The following is a description of a gene set: Human Gene Set: GSE23308_CTRL_VS_CORTICOSTERONE_TREATED_MACROPHAGE_MINERALCORTICOID_REC_KO_DN from publication Usher MG, Duan SZ, Ivaschenko CY, Frieler RA, Berger S, Schütz G, Lumeng CN, Mortensen RM (PMID 20697155) studied in species Homo sapiens Inappropriate excess of the steroid hormone aldosterone, which is a mineralocorticoid receptor (MR) agonist, is associated with increased inflammation and risk of cardiovascular disease. MR antagonists are cardioprotective and antiinflammatory in vivo, and evidence suggests that they mediate these effects in part by aldosterone- independent mechanisms. We used affymetrix to characterize the effect of Mineralocorticoid Receptor deletion on macrophage transcriptional profile, and identify its requirement in normal glucocorticoid signalling. Genes down-regulated in macrophages with NR3C2 knockout: untreated versus corticosterone., and this is the list of marker genes: NFIA, AP1S2, PSMB7, NFXL1, DCTPP1, RCSD1, SERPINE1, E2F8, RUFY3, B4GALT1, IRF1, ENDOD1, RIPK2, VCAM1, GEM, VOPP1, MOB1B, MOCOS, TSTD2, SEC23A, GLB1, SAT1, IL1A, SLAIN2, HINT3, RNF115, XIAP, DEK, CWC15, TOX4, ACADSB, B4GALT6, TCF4, TP53INP2, SNRPB2, TMED5, TUBB2A, SIAH2, SLC16A7, GLOD4, FNBP4, HERC1, CLIP1, ST13, RAB29, TEP1, CCNJ (cyclin J), IL10RA, WDR46, CHUK, PPT1, NFKB1, CAAP1 (NCBI Gene Id 79886), ZC3H7A, GSS, PDCD4 (NCBI Gene Id 27250), ARRDC4, RNASE4, SPAG7, AGPAT3, STK4, HMGB2, PHKB, MTMR14, TNS1, SGCB, SNRPC, KLHL25, CASP3, CMPK2, MALAT1, TRAPPC2B, PRC1, DYNC1H1, ARHGEF3, EDEM1, ARHGAP21, APTX, DPY30, CNOT7, WDR36, ARRB1, RYR1, CCPG1, MPC1 (NCBI Gene Id 51660), DHPS, ARHGAP4, B3GALNT1, SH3BP5, SEMA4D, PFKP, ABCB7, NFKBIE (NCBI Gene Id 4794), ANKRD44, ABCC1 (ATP binding cassette subfamily C member 1 (ABCC1 blood group)), THRA, APAF1, IDH1, ATP5F1C, TRIM21, LIG1, DOCK7, RBM7, RTRAF, PCNX1, DLAT, TMLHE, GTF2B, METTL5, IDH3G, STX6, ITSN2, SLC29A1, PARVG, HBS1L, MTCP1, COX15, SOCS1, PHTF2, TBK1, NOA1, PDLIM5, TRAM1, CSF1 (colony stimulating factor 1), CYB5A, TMEM184B, ENPP4, HMGB3, LIN9, RGS1, SPIN1, MRPS28, SMIM30, SYAP1, SYNCRIP, TOMM70, HAUS4, PYGL, MFSD6, HOMER1, NBN, N4BP2L1, SSR3, NCAPG2 (non-SMC condensin II complex subunit G2), GLA, MEDAG, BORCS7, CXCL3, PALS2, NDUFA9, PARG, MEF2C, ERBIN, MPV17, CAV2, FBXO42, NAA20, ELF1, STOM, RAB23, FBXL3, CYTH1, APOM, DEDD, TRIP13, HLA-B, STARD8, STT3B, SOWAHC, CELF2, MARVELD1 (MARVEL domain containing 1), CD28, MTMR6, PLPP3, ENC1, DYNC1I2, TRIM25, IVNS1ABP, CEP290, FBXW11, CBX7, CHAC2, MXI1, MSANTD2, PTGR3, PHACTR2, MCM6, CUL1, ZC3H15, SCFD1, HMGN3, IMMT, ITCH, RIDA, RAB13, NGLY1, TMEM242, GCA, TASOR2, SLC4A7